Given this list of marker genes TAPBP, TNFAIP8, GRK6, SIPA1, MBD2, VAV1, INPP5D, RAC2, HLA-C, PSMB8, CORO7, DOCK2, CSK, CD53, SP110, LIMD2, HLA-B, ARHGDIB, LAPTM5, CORO1A, HLA-A, CD48, TRIM38, PSMB10, STAT6, PTPRC, HLA-E (NCBI Gene Id 3133), HCLS1, HLA-F, SASH3, PTPN6, PHF11, here is a description of the gene set: Human Gene Set: GNF2_CD48 species: Homo sapiens Neighborhood of CD48 CD48 molecule in the GNF2 expression compendium Neighborhood of CD48